Given this list of marker genes CDKL5, MSI2 (musashi RNA binding protein 2), RBFOX1, FAM174A, RAB5IF, KMT2A, LMNTD1, CCDC157, KLF3, NRBP2, UBE3A, MINDY1, INPPL1, C1RL, JMJD8 (jumonji domain containing 8), BRD1, SEMA3F, LMX1A (NCBI Gene Id 4009), ARRDC2, MAP3K10 (NCBI Gene Id 4294), RNF181, SEPTIN10, KIF19, ATP2A2, CACUL1, KLF8, TGIF2-RAB5IF, CALU, HOMER1 (homer scaffold protein 1), PHF13, NEO1, PSD3, CARD8, KMO (kynurenine 3-monooxygenase), KLF7, LSM14B, JAZF1, AMOTL1, FAM219B, HEPACAM2, PDGFC, PTPN11, PPT2, XYLT2, RWDD2B, FAN1, PHKG2, YIPF4, CRLF3 (NCBI Gene Id 51379), CNOT9, RPS6KA4, SYT4 (NCBI Gene Id 6860), FAM91A1, DDR1, NUP153, KYAT1, ITGA6 (NCBI Gene Id 3655), PHF8, SRSF1, SAMD9, CLSTN3, CLOCK, CLXN, E2F8, STON2, NAV2 (neuron navigator 2), TTC17, JADE3, UST, ALKBH7, PLXNA3, LRFN4, ELAVL2, EYA4, MEI1 (NCBI Gene Id 654123), PPP1R16B, BLVRA, LONRF2, ZC3H6, HERC3, ACVR2B, ETV3, TEF, KSR2, here is a description of the gene set: from publication Chen Y, Wang X (PMID 31504780) Genes predicted to be targets of miRBase v22 microRNA hsa-miR-6793-3p in miRDB v6.0 with MirTarget v4 prediction scores > 80 (high confidence targets). species: Homo sapiens Human Gene Set: MIR6793_3P